The following is a description of a gene set: Human Gene Set: GSE21379_TFH_VS_NON_TFH_SAP_KO_CD4_TCELL_UP CD4 T cell help is critical for both the generation and maintenance of germinal centers, and T follicular helper (TFH) cells are the CD4 T cell subset required for this process. SAP (SH2D1A) expression in CD4 T cells is essential for germinal center development. However, SAP-deficient mice have only a moderate defect in TFH differentiation as defined by common TFH surface markers. CXCR5+ TFH cells are found within the germinal center as well as along the boundary regions of T/B cell zones. Here we show that germinal center associated T cells (GC TFH) can be identified by their co-expression of CXCR5 and the GL7 epitope, allowing for phenotypic and functional analysis of TFH and GC TFH populations. Here we show GC TFH are a functionally discrete subset of further polarized TFH cells, with enhanced B cell help capacity and a specialized ability to produce IL-4 in a TH2-independent manner. Strikingly, SAP-deficient mice have an absence of the GC TFH subset and SAP- TFH are defective in IL-4 and IL-21 production. We further demonstrate that SLAM (Slamf1, CD150), a surface receptor that utilizes SAP signaling, is specifically required for IL-4 production by GC TFH. GC TFH cells require IL-4 and IL-21 production for optimal help to B cells. These data illustrate complexities of SAP-dependent SLAM family receptor signaling, revealing a prominent role for SLAM receptor ligation in IL-4 production by germinal center CD4 T cells but not in TFH and GC TFH differentiation. from publication Yusuf I, Kageyama R, Monticelli L, Johnston RJ, Ditoro D, Hansen K, Barnett B, Crotty S (PMID 20525889) species: Homo sapiens Genes up-regulated in CD4 follicular helper T cells (Tfh) with SH2D1A knockout versus non-Tfh cells with SH2D1A knockout., and this is the list of marker genes: SSB, GOLM1 (NCBI Gene Id 51280), TUT7, MCRIP2, MIA2, PPP3CB, HYPK, RECQL, APLN, DHRS4, SH3TC2, SGPP1, SOS1, ACP1, UBLCP1, BCL2L13, GRB10, REEP6, CCT7, ASB17, BTAF1, NECAB3, NFS1, SLC35D1, PRKAG1, UGCG, CCNB1IP1, BCL2L15, ITGA4, TFDP2, NARF (nuclear prelamin A recognition factor), PLXNC1, STOM, NECAP2, RNF19A, GCLM, PIP4K2C, DPY19L4, KEL, PEX5, OPTN, ABCB10, ARFGAP3, PRDX6, PTPN3, YOD1, NDUFAF4, GFI1B, COX17, CISD1, FECH, PSMC2, ALKBH8, PXMP2, ADD1, GAPVD1, BAG4, CECR2, BLVRB, LDHC, WDFY3, MEX3D, BEX4, PRCP, KLHL12, APLP2, PIKFYVE, ENO3, EPB41, STRADB, HAGH (hydroxyacylglutathione hydrolase), TPRKB, ACYP1, ATP1B2, SLC25A30, FHIT, XPNPEP1, POLR1D, TOP1, FXN, CYTH3, MMP14, SHCBP1L, MINPP1, TNFAIP2, PIN4, CCNE1, ZNF239, EPDR1, HK1, MTHFD1, RBKS, PGAP4, SELENOT, AGAP1, CHRM3, TPST1, TRAPPC10, C1QTNF12, ANK1 (NCBI Gene Id 286), MRPS23, PRDX2 (peroxiredoxin 2), MCCC2, PVT1, PRKRA, WDR35, NQO1, SAMD14, AK7, PSME3, ZMAT3, SLC12A4, RIF1, STX2, ADGRE5, STRBP, GDPD1, POLR1F, GAREM1, TENT5C, PDLIM1, RB1, NOL8 (NCBI Gene Id 55035), UTP15, MTR, GLRX2, CDKN2C, EXOC6, HYCC1, ZFPM1, DDIAS, GPR155, C1orf50, MYO18B, KLF1, ABCA3, TBRG4, GPAM, SH3GLB1, HOXB13 (NCBI Gene Id 10481), CA2, PLA2G4C, DAAM1, STARD10, TRMT61A, GSTM3, FZD7, PCYT1A, ZDHHC14, EPB41L5, ABCB6, ATP5MC1, SSX2IP, SLC26A1, HDAC7, KYAT1, HPN, NKX1-2, USF3, ELL2, GLRX5, CA1, CTPS1, C5orf22, KLF3, NUDCD2, MGLL, CPOX, MAGEB16, BLM, TBC1D8B, ADD2, SCML2, AREL1 (apoptosis resistant E3 ubiquitin protein ligase 1), ATP13A3, SLC43A1, HIF3A, POLR3E, EIF4A1, IBA57, USP36, DHX9, MRAP, BSND, RETREG3, CEP41, ZNF266, ZNF251, TEX9, TNK2, C19orf67 (NCBI Gene Id 648272), CA13, RCAN1, MFHAS1, DUSP11 (dual specificity phosphatase 11), NUP214, COMMD5, L3MBTL2, ENDOD1, CCNG1